The following is a description of a gene set: A type of autophagy where cytosolic components are ingested by late endosomes, lysosomes or yeast-type lytic vacuoles by direct invagination of the compartment membrane without prior sequestration into an autophagosome. The engulfing membranes fuse, resulting in the lysosomal delivery of the cargo wrapped in a single membrane derived from the invaginated lysosomal membrane. species: Mus musculus Mouse Gene Set: GOBP_MICROAUTOPHAGY, and this is the list of marker genes: Rb1cc1, Snx30, Atg5, Atg9b, Ulk3, Atg9a, Zfp418, Hspa8, Atg2b, Atg4c, Atg2a, Atg16l1 (autophagy related 16 like 1), Atg4a, Atg4a-ps, Ulk1, Vps4a, Atg12, Atg7, Vps4b, Atg4d, Ulk2, Atg4b, Atg13, Snx7